The following is a description of a gene set: species: Mus musculus Mouse Gene Set: GOBP_VIRAL_BUDDING_VIA_HOST_ESCRT_COMPLEX Viral budding which uses a host ESCRT protein complex, or complexes, to mediate the budding process., and this is the list of marker genes: Chmp5, Tsg101, Chmp4c, Chmp2a, Chmp1b, Chmp6, Vps4b, Vps4a, Chmp3, Vps37b, Chmp4b, Chmp1a, Chmp1b2, Pdcd6ip, Chmp7, Chmp2b (charged multivesicular body protein 2B)